The following is a description of a gene set: Clathrin-mediated endocytosis studied in species Homo sapiens Human Gene Set: REACTOME_CLATHRIN_MEDIATED_ENDOCYTOSIS, and this is the list of marker genes: FCHO2, CLTCL1, ARFGAP1, ARPC2, CLTA, CFTR, TF, ACTB, GRK2, SNX9, LDLR, CBL, SLC18A3, SYT9, HBEGF, EGF, FCHO1, AGFG1, NEDD8, ITSN2, AREG, VAMP8, EPN2, NECAP2, GPS1, PACSIN3, RPS27A, UBC, CLTC, APOB, BTC, COPS2, VAMP3, STON2, SYT2, CHRM2, TACR1, DVL2, SH3GL2, SNAP91, ACTR2, RAB5B, GRB2, ARRB1, ACTR3, CD3D, AP2B1, SYT11, EPN1, TOR1A, GAPVD1, M6PR, LRP2, ARRB2, EPS15L1, COPS6, UBQLN2, PICALM, VAMP7, PIP5K1C, HGS, ADRB2, ARPC3, RAB5A, COPS5, COPS7A, STAM2, HSPA8 (heat shock protein family A (Hsp70) member 8), SYT1, CTTN, SNX18, TFRC, COPS8, AP2M1, ITSN1, OCRL, PIK3C2A, SH3GL3, SH3GL1, SYT8, TGFA, DNM1, NECAP1, PACSIN2, SGIP1, REPS1, DNM3, CD3G, UBQLN1, UBA52, EPS15, HIP1, SYNJ1, STON1, AVP, AAK1, TGOLN2 (NCBI Gene Id 10618), IGF2R, IL7R, AP2A2, EGFR, SH3KBP1, ARPC4, REPS2, STAM, TRIP10, AGTR1 (NCBI Gene Id 9449), DNM2, VAMP2, DNAJC6, GRK3, CLTB, COPS3, BIN1, PACSIN1, SLC2A8, EPGN (epithelial mitogen), ACTG1, WNT5A, ARPC1A, ARF6, EREG, DAB2, UBB, TOR1B, CD4, AP2A1, AVPR2, AP2S1, GAK, LDLRAP1, RAB5C, SCARB2, KIAA0319, HIP1R, SYNJ2, WASL, ARPC5 (actin related protein 2/3 complex subunit 5), FNBP1L, AMPH, FZD4, COPS4, VAMP4, FNBP1, COPS7B